The following is a description of a gene set: studied in species Homo sapiens Signaling by CSF3 causes its own inactivation, thereby preventing overproliferation of neutrophils. Activated CSF3R recruits and activates JAK2, which phosphorylates STAT1, STAT3, and STAT5. The phosphorylated STATs transit to the nucleus and enhance the expression of SOCS1 and SOCS3, inhibitors of CSF3R signaling (inferred from mouse homologs). SOCS3, the principle negative regulator, binds the phosphorylated C-terminal region of CSF3R and acts in two ways: direct inhibition of the phosphorylation activity of JAK2 (van de Geijn et al. 2004) and promotion of endocytosis and ubiquitination of CSF3R. part of: Signaling by CSF3 (G-CSF) Reactome Pathway: Inactivation of CSF3 (G-CSF) signaling, and this is the list of marker genes: UBC, ELOC, SYK, UBA52, STAT5B, STAT1, SOCS1, HCK, UBE2D2, CUL5, CSF3, TYK2, SOCS3, RNF7 (ring finger protein 7), ELOB, UBE2D1, LYN, STAT5A, STAT3 (NCBI Gene Id 6774), CSF3R, JAK1, UBB, RPS27A, UBE2D3, JAK2 (Janus kinase 2)